Given this list of marker genes Gm16463, Tsga8, Gm14774, Gk, Ppp4r3c-ps, Mageb11, Gm14773, Gm8855, Mageb8-ps, Nanog-ps1, Gm8839 (NCBI Gene Id 667841), Gm18439, Gm8844, Rpl10-ps4, Gm18438, Mageb7-ps, Ppp4r3c2, Gm24470 (predicted gene, 24470), Gm5759, Fthl17a (NCBI Gene Id 71996), Gm41, Gm649, Mageb10-ps, Samt3, Tasl, Fth1-ps, Nr0b1, Il1rapl1, Gm14797, Dcaf8l, Gm6973, Gm14766, Tab3, Gm14794, Gm7108 (predicted gene 7108), Gm14769, Dmd, Gm14795, Gm8858, Gm14772, Gm14741, Mageb6-ps, Gm25006, Gm4746, Gm14739, Gm16412, Ppp4r3c1, Gm14776, Gm6964, Gm6027, Mageb4, Gm8880 (NCBI Gene Id 674317), Mir1906-2, Gm14804, Gm8876, Gm8864, here is a description of the gene set: studied in species Mus musculus Mouse Gene Set: chrXC1